Given this list of marker genes Zc3h8, Erbb2, Lgals9, Foxj1, Adam8, Zfp609 (zinc finger protein 609), Bmp4, Ankle1, Il2rg, Tox, Clec4g, Zfp608, Vnn1, Rasgrp1, Il7r, Sos1, Cdkn2a, Clptm1, Sos2, Egr3, Ada, Ptpn2, Tmem131l, Adrm1, Shh, Ihh, Tespa1, Skint1, Nfkbid, Rag2, Zeb1, Foxn1, here is a description of the gene set: Mouse Gene Set: GOBP_REGULATION_OF_T_CELL_DIFFERENTIATION_IN_THYMUS Any process that modulates the frequency, rate or extent of T cell differentiation in the thymus. species: Mus musculus